Given this list of marker genes BRCA1, EYA4, SUMO1, PIAS4, KAT5, H2BC1, H2BC12, RPS27A (ribosomal protein S27a), ABL1, H3-4, UBE2I, H2BC3, H2BC12L, EYA3, H2BC17, RNF8, EYA2, MDC1, RAD50 (RAD50 double strand break repair protein), BAP1, RNF168, EYA1, BABAM1, UBA52, H2BC11, H2BC14, UBXN1, CHEK2, APBB1, UBC, H2BC5, PPP5C, H2BC4, HERC2, TP53, KDM4B, H2BC15, MRE11, H2BC26, TP53BP1, UIMC1, BRCC3, ATM, UBE2N, H2BC9, UBE2V2, H4C1, SMARCA5, ABRAXAS1, H2BC21, BARD1, H2BC13, NBN, BAZ1B, UBB, NSD2, BABAM2, H2AX, MAPK8, KDM4A, here is a description of the gene set: studied in species Homo sapiens part of: DNA Double Strand Break Response Activated ATM phosphorylates a number of proteins involved in the DNA damage checkpoint and DNA repair, thereby triggering and coordinating accumulation of DNA DSB repair proteins in nuclear foci known as ionizing radiation-induced foci (IRIF). In general, proteins localizing to the nuclear foci in response to ATM signaling are cooperatively retained at the DNA DSB site, forming a positive feedback loop and amplifying DNA damage response.<p>Activated ATM phosphorylates the NBN (NBS1) subunit of the MRN complex (MRE11A:RAD50:NBN), as well as the nucleosome histone H2AFX (H2AX) on serine residue S139, producing gamma-H2AFX (gamma-H2AX) containing nucleosomes. H2AFX is phosphorylated on tyrosine 142 (Y142) under basal conditions. After ATM-mediated phosphorylation of H2AFX on S139, tyrosine Y142 has to be dephosphorylated by EYA family phosphatases in order for the DNA repair to proceed and to avoid apoptosis induced by DNA DSBs. Gamma-H2AFX recruits MDC1 to DNA DSBs. After ATM phosphorylates MDC1, the MRN complex, gamma-H2AFX nucleosomes, and MDC1 serve as a core of the nuclear focus and a platform for the recruitment of other proteins involved in DNA damage signaling and repair.<p>RNF8 ubiquitin ligase binds phosphorylated MDC1 and, in cooperation with HERC2 and RNF168, ubiquitinates H2AFX and histone demethylases KDM4A and KDM4B.<p>Ubiquitinated gamma-H2AFX recruits UIMC1 (RAP80), promoting the assembly of the BRCA1-A complex at DNA DSBs. The BRCA1-A complex consists of RAP80, FAM175A (Abraxas), BRCA1:BARD1 heterodimer, BRCC3 (BRCC36), BRE (BRCC45) and BABAM1 (MERIT40, NBA1)<p>Ubiquitin mediated degradation of KDM4A and KDM4B allows TP53BP1 (53BP1) to associate with histone H4 dimethylated on lysine K21 (H4K20Me2 mark) by WHSC1 at DNA DSB sites.<p>Once recruited to DNA DSBs, both BRCA1:BARD1 heterodimers and TP53BP1 are phosphorylated by ATM, which triggers recruitment and activation of CHEK2 (Chk2, Cds1).<p>Depending on the cell cycle stage, BRCA1 and TP53BP1 competitively promote either homology directed repair (HDR) or nonhomologous end joining (NHEJ) of DNA DSBs. HDR through homologous recombination repair (HRR) or single strand annealing (SSA) is promoted by BRCA1 in association with RBBP8 (CtIP), while NHEJ is promoted by TP53BP1 in association with RIF1. Reactome Pathway: Recruitment and ATM-mediated phosphorylation of repair and signaling proteins at DNA double strand breaks